Given this list of marker genes TXNL1, STK38, HSP90AB1, VIM, SRRM1, TMOD3 (NCBI Gene Id 29766), HSP90AA1, RBBP6, HNRNPC, ACTN1 (actinin alpha 1), CCT2, SPEN, RHOBTB2, ROCK1, PHIP, CDC37 (cell division cycle 37, HSP90 cochaperone), COPS4, TWF1, CPSF7, ACTG1, TRA2B, MYO6, DBN1, RHOBTB1, CUL3, ROCK2, RBMX, COPS2, DDX39B, RNF20, CCT7, PDE5A, MSI2, CCT6A, GPS1, here is a description of the gene set: Human Gene Set: REACTOME_RHOBTB_GTPASE_CYCLE RHOBTB GTPase Cycle species: Homo sapiens